The following is a description of a gene set: An acute dystonic reaction with blepharospasm, periorbital twitches, and protracted fixed staring episodes. There may be a maximal upward deviation of the eyes in the sustained fashion. Oculogyric crisis can be triggered by a number of factors including neuroleptic medications. studied in species Homo sapiens Human Gene Set: HP_OCULOGYRIC_CRISIS Oculogyric crisis, and this is the list of marker genes: DDC, GRIN1, PTS (6-pyruvoyltetrahydropterin synthase), DNM1L, PCBD1, ATP13A2, DNAJC12, SLC18A2, SPR, TH, ACTB, TSPOAP1, SLC6A3